The following is a description of a gene set: from publication Le N, Nagarajan R, Wang JY, Araki T, Schmidt RE, Milbrandt J (PMID 15695336) studied in species Mus musculus Human Gene Set: LE_EGR2_TARGETS_DN Egr2 is a transcription factor required for peripheral nerve myelination in rodents, and mutations in Egr2 are associated with congenital hypomyelinating neuropathy (CHN) in humans. To further study its role in myelination, we generated mice harboring a hypomorphic Egr2 allele (Egr2Lo) that survive for up to 3 weeks postnatally, a period of active myelination in rodents. These Egr2Lo/Lo mice provided the opportunity to study the molecular effects of Egr2 deficiency on Schwann cell biology, an analysis that was not possible previously, because of the perinatal lethality of Egr2-null mice. Egr2Lo/Lo mice phenocopy CHN, as evidenced by the severe hypomyelination and increased numbers of proliferating Schwann cells of the peripheral nerves. Comparison of sciatic nerve gene expression profiles during development and after crush injury with those of Egr2Lo/Lo Schwann cells revealed that they are developmentally arrested, with down-regulation of myelination-related genes and up-regulation of genes associated with immature and promyelinating Schwann cells. One of the abnormally elevated genes in Egr2Lo/Lo Schwann cells, Sox2, encodes a transcription factor that is crucial for maintenance of neural stem cell pluripotency. Wild-type Schwann cells infected with Sox2 adenovirus or lentivirus inhibited expression of myelination-associated genes (e.g., myelin protein zero; Mpz), and failed to myelinate axons in vitro, but had an enhanced proliferative response to beta-neuregulin. The characterization of a mouse model of CHN has provided insight into Schwann cell differentiation and allowed the identification of Sox2 as a negative regulator of myelination. Genes down-regulated in P14 nerves of transgenic mice having hypomorhic (reduced function) allele of EGR2., and this is the list of marker genes: FGF7, CDKN1A, FDPS, AK3, RTN1, SLC6A15, FAAH, SEMA3B (NCBI Gene Id 7869), OGN, TIPARP, SNCA (synuclein alpha), COX8BP, SLC1A5, S100B, ELOVL6, MAL, TLCD4, FGF1, FUT8, TKT, MT1X, ADIPOQ, SEMA6C, CMTM6, GLOD4, ITPKB, SERPIND1, CLTB, LSS, NR4A2, THRSP, SLC25A1, SULT1A1, S100A1, UGT8, PCMT1, PIM3, MPDZ, PCYT2, LPL, NSDHL, UTRN, ADAM10, PCK1, PRX, ABCB1 (ATP binding cassette subfamily B member 1), MVD, MBP, FGL2, CD55, MYO1D, LIMCH1, EPHB6 (EPH receptor B6), RGCC, CERS2, IDI1, LOX, CD9, SLC2A1, PIK3R1, CA3, OSBPL5, KCNK1, HMGCR, TMEM30A, PEA15, SIRT2, GJB1, TMEM40, SCD, PMP22, MGST3, FTH1, MSMO1, MYH11, CLDN5, NRBP2, CPEB2, ERRFI1, ZBTB16, PTGDS, MT3, IL16 (NCBI Gene Id 3603), MAPK8IP1, CAT, RAP1GDS1, MAST2, TGFA, NDRG1, SNCG, EMP2, HMGCS1, GNAI1, RNF13, ME1, ABCA2, MPZ, FADS1, EFHD1, CHST2, MYO1B, CYP51A1, SCN7A, FDFT1, NACC2, GFRA1, SLCO3A1